The following is a description of a gene set: from publication Chen Y, Wang X (PMID 31504780) studied in species Mus musculus Genes predicted to be targets of miRBase v22 microRNA mmu_miR_6999_5p in miRDB v6.0 with MirTarget v4 prediction scores > 80 (high confidence targets). Mouse Gene Set: MIR_6999_5P, and this is the list of marker genes: Trim32, Cflar, AI593442, Blnk, Prrx1, Ccl6, Eny2, Cby2, Nr5a1, Spata17, Setbp1, Als2, Atg13, Nf2, Hnf4a, Erv3, Trmt10a, Cdkl3, Shisa9, Fry, Gin1, Cd274, Krt34, Smarcc1, Snrpc, Syt12, Dok5, Itga3, Mthfd2l (methylenetetrahydrofolate dehydrogenase (NADP+ dependent) 2-like), Snhg11, Ap1s1, A2ml1, Rnf150, Tmem252 (NCBI Gene Id 226040), Tmem184b (transmembrane protein 184b), Lrrtm2, Zfp169, Atp6ap1, Spin1, L2hgdh, Slc16a14, Nipsnap1, Pip4p1, St3gal1, Nop9, Mmp17, Atf7, 7530416G11Rik, Fam234b, Esp36, Lekr1, Suox, Htr2c, Trim67, Ppp1r18, Parp8, Dnase2b, Umps, Cdc14b, Tal1, Gpr132, Ncapd3, Mecom, Psme3, Satb2, Hif3a (hypoxia inducible factor 3, alpha subunit), Sav1, Patl2, Tbx5, Ap1s3, Parpbp, Sfxn3, Dab2ip, Ctns, Vldlr, Jakmip1, Nabp2, Tsc22d2, Rab6b, Cysltr1, Pkd2, Cd300lb, Pgrmc2, Morc4, Enah, Plxna2, Slc23a2, Enpp4, Brap, Klhl20, Slc3a2, Spred1, Pde6a, Car10, Nab1, Atp8b2, Epha8, Ulk3, Pfas, Sh3gl2, Pcdhb3, Sec16b, Spidr, Cct8, Zfp592, Chad, Car8, Bard1, Elmo1, Crebrf, Slc2a2, Ankrd13c, Trrap, Rusc1 (NCBI Gene Id 99477), Pfkfb3, Spock2, Hmg20a, Zfp664, Fzd3, Ptafr, Srgap2, Zfp937, Sec61g, Aqp7, 2210408I21Rik, Erich3, Kdm5a, Wipf2, Tshz2, Rtbdn, Stim1, Hpgd, Cdh8, Mprip, Gbf1, Tmem138, Zbtb4, Sh2d1b1, Zfp395, Gpatch8, Tle1, Dnajc1, Prrg3, Smchd1, Nalcn, Asph, Jchain, Mcc, Emp2, Matcap1, Chrdl1, Sez6l, Col12a1, Zdhhc5, Smg6, Ttpal, Tlcd5, Msx3, Pdk4, Prl5a1, Dnaja4, C5ar1, Zfp775, Atg4c, Fgf16, Siglecl2, Arhgap10, Blmh, Kynu, Dusp22, Slc25a51, Zbtb16, Seh1l, Abhd12, Ednrb, Gpank1, Btf3l4, Tmx4, Syt14, Onecut2, Add1, Ttc41, Zeb2, Bcam, Marchf5, Scimp, St7l (suppression of tumorigenicity 7-like), Nxf3, Grik3, Ralgapa2, Clcc1, Osbp, Cxcl9, Dip2c, Gucy1a2, Kalrn, Picalm, Tead1, Thsd4, Cd300lg, Ripor2, Lrrc39, Ssh2, Dmtf1l, Ebf2, Kmt2c, Mrps2, Rap1gds1, Usp46, Prkacb, Abcb7, Pax1, Sdc4, Esrrg, Traf1, Map3k5, Oxsm, Sec62, Sfxn4, Daam2, Myoz3, Fam168a, Crisp2, Atp6v1d, Cep43, Prkn, Pik3c2b, Emc6, Hook3, Creb5, Inka2, Thra, Jph4, Ppp1r14c (protein phosphatase 1, regulatory inhibitor subunit 14C), Shisa7, Pacs1, Fancg, Ttc13, Cdk6, Ptpre, Jam3, Ado, Rbbp4, Ncr1, Slc13a4, Ica1l, Nav1, Gid4, St8sia1, Ptar1, Mylk4